Given this list of marker genes TACR2, CRHR1, CRH, C1QTNF1, APLN, FOXL2, F2RL1, KDM5B, NPVF, GAL, CRY2 (cryptochrome circadian regulator 2), AGTR1, INHBA, RAB8B, DAB2, BMP6, INHBB, TSPO, GDF9, POMC, TAC1, CRHBP, GJA1, GJA5, INHA, KCNK9, F2R, PTPN11 (protein tyrosine phosphatase non-receptor type 11), UCN, RETN, SMAD4, NKX3-1, CYP19A1, OR51E2, AGT, LEP, GHRL, SPP1, REN, ECRG4, CRY1, FGFR1, GALR1, OPRK1, here is a description of the gene set: Any process that modulates the frequency, rate or extent of an endocrine process, a process involving the secretion of or response to endocrine hormones. An endocrine hormone is a hormone released into the circulatory system. species: Homo sapiens Human Gene Set: GOBP_REGULATION_OF_ENDOCRINE_PROCESS